Given this list of marker genes Dnm2, Ap3b2, Slc2a4, Ap3m2, Mx2, Btbd8, Ap3s2, Ap3d1, Arf1 (ADP-ribosylation factor 1), Dnm3 (dynamin 3), Ap3s1, Dnm1, Ap1s2, here is a description of the gene set: Mouse Gene Set: GOBP_SYNAPTIC_VESICLE_BUDDING Evagination of a membrane to form a synaptic vesicle. species: Mus musculus